Given this list of marker genes H2-M2, H2-M10.2, H2-M9, H2-T3 (NCBI Gene Id 547339), H2-M1 (NCBI Gene Id 333725), H2-M5, H2-T22, H2-M11, B2m, H2-M10.1, H2-M10.4, H2-M10.5, H2-Q7 (histocompatibility 2, Q region locus 7), H2-Q4, H2-Q2, H2-D1, H2-M10.6, H2-Q6, Mr1, H2-K1, H2-Q10, H2-Q1, H2-T23, H2-T10, H2-M10.3, here is a description of the gene set: Mouse Gene Set: GOCC_MHC_CLASS_I_PROTEIN_COMPLEX A transmembrane protein complex composed of a MHC class I alpha chain and an invariant beta2-microglobin chain, and with or without a bound peptide antigen. Class I here refers to classical class I molecules. studied in species Mus musculus